The following is a description of a gene set: species: Mus musculus Cluster PAM3: genes most highly up-regulated in hepatocellular carcinoma (HCC) vs normal liver tissue from mice deficient for TXNIP. from publication Sheth SS, Bodnar JS, Ghazalpour A, Thipphavong CK, Tsutsumi S, Tward AD, Demant P, Kodama T, Aburatani H, Lusis AJ (PMID 16607285) The molecular pathogenesis and the genetic aberrations that lead to the progression of hepatocellular carcinoma (HCC) are largely unknown. Here, we demonstrate that the thioredoxin interacting protein (Txnip) gene is a candidate tumor suppressor gene in vivo. We previously showed that the recombinant inbred congenic strain HcB-19 has a spontaneous mutation of the Txnip gene, and we now show that the strain has dramatically increased incidence of HCC, and that the HCC cosegregates with the Txnip mutation. Approximately 40% of the Txnip-deficient mice developed hepatic tumors with an increased prevalence in male mice. Visible tumors develop as early as 8 months of age. Histological analysis confirmed the morphology of HCC in the Txnip-deficient mice. Molecular markers of HCC, alpha-fetoprotein and p53, were increased in tumors of Txnip-deficient mice. The upregulation of p53 preceded tumor development; however, bromodeoxyuridine (BrdU) labeling of normal hepatic tissue of Txnip-deficient mice did not reveal increased cell proliferation. Finally, microarray analyses of tumor, non-tumor adjacent, and normal tissue of Txnip-deficient mice highlighted the genetic differences leading to the predisposition and onset of HCC. Our findings suggest that Txnip deficiency is sufficient to initiate HCC and suggest novel mechanisms in hepatocarcinogenesis. Human Gene Set: SHETH_LIVER_CANCER_VS_TXNIP_LOSS_PAM3, and this is the list of marker genes: IGDCC4, TGFBR2, OCSTAMP, NUCB2, MKI67, BMP7, SPRED1, IGFBP1, PLEK2, CALML4, FABP4, LCN2, ITIH5, DAB1, RHOC, SLPI, EHD4, UNC5B, MYEF2, SERPINE1, PROM1 (prominin 1), CCDC120, GALNT6, TMEM71, CXADR, IFIT2, AFP, CDKN2B, PSAT1, TFF3, TPM1 (tropomyosin 1), SYCP3, BEX1, MYCN, MAFF, LY6D, TUBB6, LTB, COL1A1, GYG1, CES2, ROBO1, PYGB, NUPR1, PGLYRP1, JUN, FABP5, DDR1, PHGDH, CDH1, B4GALT6, PSRC1, ESM1, TLR1, SIDT1, GPC3, AEBP1, H19, ITGA6, MCM6, MEP1B, BEX3, SPINK1, TSPAN8, ISYNA1 (NCBI Gene Id 51477, inositol-3-phosphate synthase 1), SCD, NID1, CYP17A1, CCNB1, TMEM191C, UBE2C, SPARC (NCBI Gene Id 6678), TNFRSF12A, PROM2, PCK2